The following is a description of a gene set: Selected up-regulated genes distinguishing between Wilms tumors of different histological types: anaplastic vs favorable histology. Anaplasia (unfavorable histology) is associated with therapy resistance and poor prognosis of Wilms tumor, but the molecular basis for this phenotype is unclear. Here, we used a cDNA array with 9240 clones relevant to cancer biology and/or kidney development to examine the expression profiles of 54 Wilms tumors, five normal kidneys and fetal kidney. By linking genes differentially expressed between fetal kidney and Wilms tumors to kidney morphogenesis, we found that genes expressed at a higher level in Wilms tumors tend to be expressed more in uninduced metanephrogenic mesenchyme or blastema than in their differentiated structures. Conversely, genes expressed at a lower level in Wilms tumors tend to be expressed less in uninduced metanephrogenic mesenchyme or blastema. We also identified 97 clones representing 76 Unigenes or unclustered ESTs that clearly separate anaplastic Wilms tumors from tumors with favorable histology. Genes in this set provide insight into the nature of the abnormal nuclear morphology of anaplastic tumors and may facilitate identification of molecular targets to improve their responsiveness to treatment. Human Gene Set: LI_WILMS_TUMOR_ANAPLASTIC_UP from publication Li W, Kessler P, Williams BR (PMID 15531917) studied in species Homo sapiens, and this is the list of marker genes: TTK, NUSAP1, CENPF, NCAPH, RFC4, HAT1, MKI67, HTT, G3BP2, KIF2C, CDCA3, RFC3, PCGF3, CCNA1, RAD54L, CENPA, KPNA2